The following is a description of a gene set: Most cancer deaths are due to metastasis, and epithelial-to-mesenchymal transition (EMT) plays a central role in driving cancer cell metastasis. EMT is induced by different stimuli, leading to different signaling patterns and therapeutic responses. TGF_ is one of the best-studied drivers of EMT, and many drugs are available to target this signaling pathway. A comprehensive bioinformatics approach was employed to derive a signature for TGF_-induced EMT which can be used to score TGF_-driven EMT in cells and clinical specimens. Multiple datasets were used to derive the signature using three approaches: by integrating the datasets prior to identifying EMT genes, by first identifying EMT genes from individual datasets and then combining them using a meta-analysis (product of ranks) approach, and by combining inferences from the first two approaches. from publication Foroutan M, Cursons J, Hediyeh-Zadeh S, Thompson EW, Davis MJ (PMID 28119430) studied in species Homo sapiens Genes down-regulated in the epithelial-mesenchymal transition (EMT) upon transforming growth factor beta (TGFb) stimulation derived from multiple datasets by integrating them. Human Gene Set: FOROUTAN_INTEGRATED_TGFB_EMT_DN, and this is the list of marker genes: VAV3, ESRP1, FGFBP1, EHF, DEFB1, AQP3, CFH, PLS1, SCNN1A, PLAAT4, HS3ST1, CYB5A, PPP1R9A, AGR2, TSPAN1, LCN2, ALDH1A3, EMP1, LY6E, CD9, PDK4, SLPI, EPCAM, ATP8B1, SYNE2, TBC1D8 (NCBI Gene Id 11138), CDH1, ERMP1, RAB25, ELF3, SERPINB1, FOXA2, TJP2, MPZL2, CP, KRT15, IMPA2, DST, SLC27A2, MANSC1, SLC16A7, EPB41L4B, C1orf116, DEPTOR, LSR, INHBB, MMP7, BIRC3, EREG, GRTP1, KRT19, MYO5C, MBP (myelin basic protein), FA2H, ERBB3, PPL, CEBPD (CCAAT enhancer binding protein delta), SOX2, CAVIN2, S100P, AREG, MTUS1, TMEM30B, TMT1A, CFB, CXADR, GSE1, RBM47, HPGD, ANK3, PKP2, ARHGAP29, CEACAM6, GDF15